Given this list of marker genes Rab3ip, Bbs1, Rab8a, Tuba1b, Mchr1, Exoc1, Tuba1c, Tuba4a, Tubal3, Rab11a, Smo, Bbs2, Inpp5e, Cct8, Tuba3b, Rp2, Tuba1a, Tubb6, Asap1, Bbs7, Exoc2 (exocyst complex component 2), Cct3, Cct2, Tubb4b, Tubb2b, Tubb4a (NCBI Gene Id 22153), Cngb1, Sstr3, Cct5, Rho, Atat1, Lztfl1, Ttc8, Bbs10, Exoc7, Nphp3, Arl3, Tuba8, Cnga4, here is a description of the gene set: part of: Assembly of the 9+0 primary cilium Reactome Pathway: Cargo trafficking to the periciliary membrane species: Mus musculus electronically inferred by orthology from the curated human pathway This event has been computationally inferred from an event that has been demonstrated in another species.<p>The inference is based on the homology mapping from PANTHER. Briefly, reactions for which all involved PhysicalEntities (in input, output and catalyst) have a mapped orthologue/paralogue (for complexes at least 75% of components must have a mapping) are inferred to the other species.